The following is a description of a gene set: studied in species Mus musculus Processing of DNA double-strand break ends Mouse Gene Set: REACTOME_PROCESSING_OF_DNA_DOUBLE_STRAND_BREAK_ENDS, and this is the list of marker genes: Timeless, Abraxas1, H2bc21, Rfc3, H2bc12, H4c2, Exo1, Rps27a, H4c14, Ube2v2, Kat5, Babam1, Rmi1, H4c11, Dna2, Rfc4, H4c1, Hus1, Sirt6, H2bc3, Rad1, Rmi2, Ube2n, H2bc22, Nbn, Babam2, H2ax, Mre11a, Mdc1, Tipin, H4c4, Rnf168, Brca1, H2bc6, Rpa3, Rad9a, Ube2i, Rhno1, Ppp4r2, Clspn, Rfc2, H3f4, Rad17, H2bc15, H2bc4, Rpa2, Uba52rt, Rpa1, Cdk2, Sumo2, Chek1, Brcc3, Herc2, Top3a, Ubc, Rnf4, H2bc9, H2bc11, H4c8, Ccna1, Rad9b, Bard1, Brip1, Pias4, Rbbp8, H2bc13, H2bc24, H2bc26, Rad50, Topbp1, Ubb, H4c6, H2bc23, Wrn (Werner syndrome RecQ like helicase), Trp53bp1, H2bc8, Uimc1, Uba52, H2bc1, Nsd2, H4c12, H4c3, Blm, H2bc14, H4c16, Atm, Rfc5, H2bc7, Ppp4c, H4c18, H4c9, Rnf8, H4c17, Ccna2, Atrip